Given this list of marker genes PLCH1, PLCB1, ITPK1, PLD4, SYNJ1, INPP5J, PLCZ1, PLCG2, OCRL, INPP5B (NCBI Gene Id 3633), ITPKB, PLCE1, PLCD1, PLCG1, PLCB3, PLCD4, INPP5D, INPPL1, PLCB2, PLCB4, ITPKA (NCBI Gene Id 3706), PLCD3, ITPKC, CALM1, PLCH2, PTEN, here is a description of the gene set: species: Homo sapiens Human Gene Set: REACTOME_SYNTHESIS_OF_IP3_AND_IP4_IN_THE_CYTOSOL Synthesis of IP3 and IP4 in the cytosol